The following is a description of a gene set: from publication Chen Y, Wang X (PMID 31504780) Genes predicted to be targets of miRBase v22 microRNA mmu_miR_344e_5p, mmu_miR_344h_5p in miRDB v6.0 with MirTarget v4 prediction scores > 80 (high confidence targets). species: Mus musculus Mouse Gene Set: MIR_344E_5P_MIR_344H_5P, and this is the list of marker genes: Diaph2, Grb2, Kif2c, Wnk1, Tent4a, Pms2, Slc34a1, Syn3, Suclg2, Panx3 (NCBI Gene Id 71631), Cdc27, Dr1, Ascl2, Rb1, Sco1, Atl2, Tmem41b, Zfp287, Ranbp10, Creb5, Mxi1, Wif1, Lmnb2, Thumpd3, Rfx3, Zmym2, Synm, Arhgap1, Hmgxb4, Gna13 (NCBI Gene Id 14674), Kbtbd6, Dnah17 (dynein, axonemal, heavy chain 17), Cdyl2, Rad54l2, Pitpnm2, Pid1, Ptges3, Rora (NCBI Gene Id 319897), Cish, Cacna1e, Snx13, Nono, Mb21d2, Sgo1, Frmd4b, Tasp1, Sgcd, Bdnf, Ftsj3, Tnfsf18, Zfp992, Tnrc6c, Tada3, Scd1, Nrdc